Given this list of marker genes Sgta, Slc5a9, Lpcat2b, Ubr7, Washc4, Zfp521, Zc3h4, Galntl6, Add1, Cnnm3, Rasl12, Adipor2, Rrs1, Bicral, Chd8, Tc2n, Tex261, Csde1, Ppm1b, Creld2, Nfib, Adgrd1, Sfpq, Arfgap2, Pdzk1ip1, Strbp, Cebpg, Clcn6, Pafah1b2, Hectd4, Xpo1, Tmem169 (NCBI Gene Id 271711), Fgf9, Npbwr1, Flot2, here is a description of the gene set: Mouse Gene Set: MIR_3109_3P from publication Chen Y, Wang X (PMID 31504780) Genes predicted to be targets of miRBase v22 microRNA mmu_miR_3109_3p in miRDB v6.0 with MirTarget v4 prediction scores > 80 (high confidence targets). studied in species Mus musculus